Given this list of marker genes ZFPM2, AGK, NCAPG, RAN, CCNI2, PHC3, TSPAN17, UHRF1, NKX3-1, KLK4, NHSL3, C4orf46, SULF1, IQSEC2, OTUB2, FCGR1A, KCNIP2, CHAMP1, VPS53, CPD, ATXN7L3B, JADE3 (jade family PHD finger 3), RAB10, PLCXD2, PTGES3, PROK2, AK7, NR2C2, ZNF124, WDR64, RPN2, GPR156, NUAK2, RNF168, METTL4, PIM2 (Pim-2 proto-oncogene, serine/threonine kinase), CREBRF, RP1L1, ELAC1, FLT1, NPAS4, here is a description of the gene set: Genes predicted to be targets of miRBase v22 microRNA hsa-miR-378e in miRDB v6.0 with MirTarget v4 prediction scores > 80 (high confidence targets). from publication Chen Y, Wang X (PMID 31504780) studied in species Homo sapiens Human Gene Set: MIR378E